Given this list of marker genes Lgmn, Abl1, Thbs4, App, Cd9, Ptger3, Gpr35, Myo1g, Tlr2, Cyp19a1, Tirap, Wdr1, Creb3 (cAMP responsive element binding protein 3), Ch25h, Enpp1, Gpr18 (G protein-coupled receptor 18), Nf1, Apod, Srp54a, Ccl21d, F7, Serpine1, Wnt5a, Il1a, Fcgr3, P2rx4, Il16, Gcnt1, Cxcl15, Trpm2, Gbf1, Ext1, Csf3r, Nckap1l, Stat5b, Lyn, Nbl1, Ptpn22, Tnf, Tnfsf14, Itgb7, Cxcl5, Cyp7b1, Trim55, Cxcl14, Ptger4, Msmp, Dpp4, Flt1, Ccn3, Smpd3, Selplg, Cx3cl1, Chst4, Itga2, Trem2, Cxcl3, Cx3cr1, Spi1 (NCBI Gene Id 20375), P4hb, Stk10, Kitl, Akirin1, Ccl12, Cd24a, Slamf9 (SLAM family member 9), Tnfrsf14, Ccr1l1, Camk1d, S1pr1 (NCBI Gene Id 99736), Myo9b, Itgb2, Lgals3, Gpr15, Podxl, Ppia, Ccl21a, Mapk1, Nup85, Vcam1, Fpr-rs3, S100a8, Tgfb1, Mia3, Ccl24, Asb2, Tafa4, Il17b, Add2, Ifng, Il1b, Ccr3, Lrch1, Ripk3, Jaml, Akt1, Pde4d, S100a14, Dpep1, Fut7, Pik3r1, Dbh, Tnfsf4, Edn2, Defb25, Plcb1, Ptprj, Cd34, Cd99l2, Umod, Cd200 (NCBI Gene Id 17470), Gpsm3, Gas6, Tacr1, Ccl19-ps4, Pgf, Fam3d, Slit2, Ccl4, Jam3, Zpld2, Slc8b1 (solute carrier family 8 (sodium/lithium/calcium exchanger), member B1), Jam2, Stk39, Ninj1, Trp53, Ptn (pleiotrophin), Aif1, Ccl19, Wasl, Pde4b, Pla2g7, Cnn2, Bdkrb1, Dusp1, Vegfa, Ccl22, Itga2b, BC037156, C3ar1, Itgb2l, Prkca, Klrk1, Gcsam, Adora1, Ror2, Hc, Spns2, Aire, Ccl11, Cxcl17, Csf1r, Pdgfb, C1qbp, Adtrp, Cklf, Adam17, Ednra, Gp2, Ccl19-ps6, Padi2, Cadm1, Lyve1, Cd300a, Myo1f, Nlrp12, Pycard, Ccr2, Il17a, Il4, Emp2, Epx, Gnai1, Vav1, Oxsr1, Mmp2, S100a9, Xcl1, Cxcl12, Emilin1, Golph3, Ptafr, Nedd9, Crk, Ggt5, Pawr, Lrp12, Ascl2, Dysf, Bcr, Mcu, Mstn, Mmp14, Tnfaip6, Bsg, Itga6, Anxa1, Coro1a, Lyst, Nlrp3, Lgals9, Lbp, Gata3, Cxcr3, Ptk2, Itga4, Capn1, H2bc1, Ccl21e, Il17rc, Cxcl2, Fpr-rs4, Spp1, Kit, Cd200r1, Il12a, Tnfsf11, Jagn1, Il33, Abl2, Mospd2, Pikfyve, Ptk2b, Ecm1, Abr, Slamf8, Madcam1, Ppbp, Ccr1, Adora3, Nod2, Dnm1l, Ccr6, Cd69, Rac2 (Rac family small GTPase 2), Ccl1, Ifnb1, Med23, Cxcl16, Ccl5, Ccl25, Mdk, Ccl8, Arhgef5, Plvap, Chst2, Tbx21, Trpm4, Gdf15, Il34, Ager, P2ry12, Trem3, Mcoln2, Trem1, Itgb1, Cxcr2, Ppib, Sirpa, Fpr2, Slamf1, Rpl13a, Crkl, Gm5849, Edn3, Rin3, C5ar1, Itga3, Aoc3, Alox5, Mmp28 (matrix metallopeptidase 28 (epilysin)), Mpp1, Cxcl9, Cxadr, Tgfb2, Rabgef1, B4galt1, Il23a, Slc37a4, Cd81, Rock1, Fadd, Ccl26, Scg2, Hoxa7, Rtn4, Irak4, Artn (NCBI Gene Id 11876), Adam10, Prtn3, Ccl21f, Fpr-rs6, Ccl7, Trpv4, Perp, Lep, Icam1, Rac1, Abcc1, Syk, Il27ra, Rarres2, Gba1, Retnlg, Gpr15lg (NCBI Gene Id 70045), F2rl1, Ccl20, Cxcl1, Ano6, Mapk3, Cxcr1, Ffar2, Nkx2-3, Cdc42 (NCBI Gene Id 12540), Vegfb, Ccl27a, Msn (NCBI Gene Id 97596), Zp3, Plg, Swap70, Selenok, Ccl3, Mif, St3gal4, Gpr183, Thbs1, Il1r1, Ctsg, Fer (NCBI Gene Id 80679), Foxj1, Thy1, Grem1, Itga7, Zfp580, Itga1, Dapk2, F11r, Vav3, Pecam1, Ccl19-ps5 (C-C motif chemokine ligand 19, pseudogene 5), Hsd3b7, Cxcl13, Calr, Fut9, Wnk1, Itgal, Ripor2, Fut4, Podxl2, Crtam, Hmgb1, Vegfc, Itgb3, Rac3, Fcer1g, Pafah1b1, Edn1, Gp1ba, Tmem102, Plec, Slc12a2, Rps19 (NCBI Gene Id 20085), Csf1, Itgam, Spn, Cxcl10, Itga9, Ccl28, Cd177, Mtus1 (mitochondrial tumor suppressor 1), Stap1, Sbds, Rhoa, Myd88, Fpr-rs7, Ccr7, Mst1, Ednrb, Cd74, Prex1, Dock8, Mmp9 (matrix metallopeptidase 9), Ccl21b, Selp, Sele, Ada, Sell, Pdgfd, Ccl19-ps1, Cd47, Adam8, Tnfrsf18, Kcnn4, Cxcl11, C5ar2, Tnfsf18, Aimp1, Vegfd (NCBI Gene Id 14205), Ccl2, Elane, Eps8, Ptpro, Cmklr1, Ccl19-ps3, Bst1 (bone marrow stromal cell antigen 1), Chga, Pf4, Cnr2, Cxcr5, Il17ra, here is a description of the gene set: The movement of a leukocyte within or between different tissues and organs of the body. studied in species Mus musculus Mouse Gene Set: GOBP_LEUKOCYTE_MIGRATION